Given this list of marker genes Stk39, Fabp5, Usp37, Ppp1r12a, Mex3c (mex3 RNA binding family member C), Gpr37, Klhl1, Vmn1r45, Exoc5, Exoc6 (exocyst complex component 6), Scn3b (NCBI Gene Id 71632), Neto1, Atg4a, Taf4, Hycc2 (NCBI Gene Id 52084), Mbnl1, Znrf3, Igfbp3, Pitx2, Ccn2, Rsbn1l, Gspt1 (G1 to S phase transition 1, NCBI Gene Id 98017), Kmt2e, Ebf3, Homer3, 9230112D13Rik, Rnf135, Itsn1 (NCBI Gene Id 16443), Fbxo33, Cd1d1, Edn2, Mme, Ppfia1, Rai1, Wwp1 (NCBI Gene Id 56840), Rflna, Rgs9bp, Tdrd5, Nhsl2, Esm1, Bbx, Trit1, Manea, Vnn1, Elac1, Dhrs7b, Hspd1, Steap2, Btd, Nkain3, Esyt3, Ppp4r2, Sox13, Nfat5, Fam91a1, Tmem263, Twist1, Nup98, Nexmif, Zdhhc21, Ppm1k, Eaf2, Tmem178, Tbr1, Sh3bgrl2, Pbdc1, B3galt1, Slc39a8, Ptprh, Rasa2, Lmo4, Tle4, Crtam, Nif3l1, Plaa, Mecp2, Ankdd1b, Ccdc60, Nps, Xkr4, Taf12, here is a description of the gene set: Mouse Gene Set: MIR_5620_3P Genes predicted to be targets of miRBase v22 microRNA mmu_miR_5620_3p in miRDB v6.0 with MirTarget v4 prediction scores > 80 (high confidence targets). studied in species Mus musculus from publication Chen Y, Wang X (PMID 31504780)